The following is a description of a gene set: from publication Tabula Muris Consortium (PMID 32669714) Mouse Gene Set: TABULA_MURIS_SENIS_MARROW_GRANULOCYTE_AGEING species: Mus musculus, and this is the list of marker genes: Pglyrp1, Rps3, Prr13, Ccl6, Slpi, Cebpd, Klf2, S100a9, Ngp, Gmfg, Rpl10, S100a6, Rps9 (ribosomal protein S9), Tyrobp, Rpl13a, Pfn1, Camp, Cd63, Coro1a, Prdx5, B2m, Pkm, Cd52, Arpc1b, H3f3b, Fcer1g, Tspo, Fxyd5, S100a11, S100a8, Clic1, Fpr2, Lsp1, Alox5ap, Lcn2, Jchain (immunoglobulin joining chain), Calm1 (NCBI Gene Id 12313), Arpc3, Lgals3 (NCBI Gene Id 16854), Malat1, Rps18, Lamtor4, Orm1, Cebpe, Spi1, Hp, Mrgpra2b, Emp3, H2-K1, Anxa2, Cotl1, Gapdh, Rsrp1, Ifitm2, Cyba, Rbm3, Cfl1, Retnlg, Arrb2, Lrg1, Myl6, H2-D1, Cd9, Cdk2ap2, Tmsb4x